The following is a description of a gene set: species: Homo sapiens A hollow mass located in the skin that is surrounded by an epithelium-lined wall and is well demarcated from the adjacent tissue. Cysts are often said to be sac-like and may contain serous liquid or semisolid material. Human Gene Set: HP_CUTANEOUS_CYST Cutaneous cyst, and this is the list of marker genes: ZSWIM6, CEP57, ALX3, CTNND1, APC, KRT17, PSENEN, IFNG, TSC2, ANTXR1 (NCBI Gene Id 84168), MNX1, CDH3 (cadherin 3), EXTL3, SYT1, MSX2, TSC1, KRT6A, POFUT1, POGLUT1, KRT16, KRT6B, CDH1, KRT5, TFAP2A, VANGL1 (VANGL planar cell polarity protein 1)